Given this list of marker genes BBS5, BBIP1, TTC8, BBS1, BBS9, BBS4, BBS7, BBS2, here is a description of the gene set: Human Gene Set: GOCC_BBSOME studied in species Homo sapiens A ciliary protein complex involved in cilium biogenesis. It consists of at least seven Bardet-Biedl syndrome (BBS) proteins and BBIP10. It moves in association with IFT trains through cilia (likely as an IFT-A/B adaptor or cargo), and is required for the integrity of IFT-A and IFT-B.